The following is a description of a gene set: Human Gene Set: REACTOME_RRNA_PROCESSING rRNA processing species: Homo sapiens, and this is the list of marker genes: UTP11, MPHOSPH6, DHX37, RPS4Y1, DDX47, RPS8 (ribosomal protein S8), WDR43, IMP3, RPL34, RPS2, PES1 (pescadillo ribosomal biogenesis factor 1), RPP40, EXOSC1, EXOSC7, DCAF13, NOL12, NOL9, RPL26 (NCBI Gene Id 6154), PWP2, NIP7, RPS14, RPP25, RPL3, RPL32, RPS4X, SNU13, MRM2, DDX52, UTP20, RPL19, RPP30, RPL35A, RPL26L1, RPL12, EXOSC8, NOB1, RPL7A, EXOSC2, RPS27A, RPL21, RPL5, RPL14, RPL18A (NCBI Gene Id 6142), DIMT1, RRP9, MRM1, EXOSC10, RPL17, TFB1M, RPLP1, RPS12, UTP6, RPS23, RPL37A, TRMT112, RPS20, RPL27, EXOSC6, BYSL, RPL13A, UTP18, NOL11, RPLP2, RRP7A (ribosomal RNA processing 7 homolog A), DKC1, MT-RNR2, RPL10L, RPL3L, ERI1, RPS4Y2, ISG20L2 (NCBI Gene Id 81875), FAU, RPL39, CSNK1E, RPS3A, RPP21, RPP38, RPL22, WDR12, RPL38 (ribosomal protein L38), BUD23, DIS3, RPL10A, RPL9, C1D, RPL30, RPS27L, NOP10, TSR3, RPL35, RPS29, RPS11, PDCD11 (programmed cell death 11), RPSA, RPS28, XRN2, EBNA1BP2, RBM28, RPS17, TEX10, RPS26, UTP15, RRP1, HEATR1, EXOSC4, LAS1L, HSD17B10, WDR3, UBA52, RRP36, RPS9, RPS5, RPS3, RPS13, RPS15, MTREX, RPP14, NHP2, GAR1, RPS21, RPL41, RPL27A, RPL4 (ribosomal protein L4), WDR18, RPL15, MPHOSPH10, MRM3, UTP25, UTP14A, WDR36, NCL (NCBI Gene Id 4691), RPS7, RPL10, EXOSC3, RPL31, RPL36AL, RPL8, WDR75, RPS27, SENP3, EXOSC5, RPL36, RPL39L, RPS18, RPL23A, IMP4, RPL11, BMS1, RPS15A, RPS19, CSNK1D, EMG1, PNO1, LTV1 (NCBI Gene Id 84946), UTP14C, NAT10, PELP1, NOP56 (NOP56 ribonucleoprotein), DDX21, NOP2, NOL6, RPS24, FCF1, NOP58 (NCBI Gene Id 51602), EXOSC9, UTP3, MT-RNR1 (mitochondrially encoded 12S rRNA), RPS10, NSUN4, THUMPD1, RPL13, RPS16, TRMT10C, TBL3, RPS6, NOP14, RPL6, RPL22L1, RPS25, PRORP, RIOK3, MTERF4, RPLP0, RPL18, UTP4, RPL36A, KRR1, RPL24, RPL23, NOC4L, DDX49, FBL, RIOK2, RCL1, FTSJ3, RPL7, RPL37, BOP1, GNL3, TSR1, WDR46, RPL29, RIOK1, RPL28, ELAC2